The following is a description of a gene set: species: Mus musculus Mouse Gene Set: GOMF_PROTEIN_SERINE_KINASE_ACTIVITY Catalysis of the reactions: ATP + protein serine = ADP + protein serine phosphate., and this is the list of marker genes: Ern2, Mark1, Dyrk2, Rock1, Cdk11b, Mos, Pask, Prkcq, Csnk2a2, Stk38l, Atm, Nek3, Dclk3, Limk2, Sgk3, Wnk4, Ulk4, Cdkl5, Prkcb, Stk40, Tesk2, Gm4922, Alpk1, Csnk1e, Map3k4, Smg1 (SMG1 nonsense mediated mRNA decay associated PI3K related kinase), Dapk3, Alpk3, Map3k15, Pgk1, Ttn, Trpm6 (transient receptor potential cation channel, subfamily M, member 6), Clk4, Map4k5, Stk38, Chek2, Rps6ka5, Nek5, Camkk2, Pak1, Mast1, Ulk3, Prkg2, Nek6, Nek8, Tnik (NCBI Gene Id 99639), Nek1, Mast4, Atr, Ttbk1, Tssk3, Eif2ak2, Smok3b, Lmtk3, Prpf4b, Cdkl1, Clk1, Map3k9, Pkn2, Map3k10, Map2k5, Prkch (protein kinase C, eta), 4921509C19Rik, Csnk1g3, Ripk1, Cdkl4, Pdpk1, Ciita (class II transactivator), Cdk16, Eif2ak4, Lmtk2, Riok3, Bub1 (BUB1, mitotic checkpoint serine/threonine kinase), Nuak1, Stk17b, Dyrk3, Prkce, Pink1, Mapk4, Slk, Taok2, Cdk12, Mapk13, Myo3b, Camk1, Nim1k, Prkg1 (NCBI Gene Id 381235), Prkacb, Tssk4, Camkk1, Smok2a, Pak5, Tssk1, Tlk1 (NCBI Gene Id 228012), Map2k6, Pim3, Csnk1a1, Tnni3k, Pkn3, Prkd2, Map2k4, Oxsr1, Pik3ca, Wnk2, Lrrk1, Dmpk, Dapk1, Phkg1, Fam20c, Eif2ak1, Pik3r4, Aak1, Stk33, Stk-ps2, Ripk4, Gak, Fastk, Hunk, Plk3, Sgk2, Csnk2a1, Pnck, Stk32b, Mapkapk3, Nlk, Bmp2k, Hipk3, Cdk2, Hipk2, Sbk1, Ulk2, Lrrk2, Melk, Mink1, Pak3, Mak, Dclk1, Lats1, Smok3a, Gsk3a, Map3k2, Nek2, Map2k1 (mitogen-activated protein kinase kinase 1), Mapk14, Braf, Raf1, Ripk3 (receptor-interacting serine-threonine kinase 3), Mapk7, Map4k4, Stk35, Map3k6, Srpk1, Mapk6, Nek4, Csnk1g1, Cdkl3, Mknk2, Stk4, Alpk2, Tesk1, Rskr, Pskh1, Map3k12, Brsk2, Ksr1 (NCBI Gene Id 51965), Mark3, Chek1, Lats2, Cdk10, Rps6kb2, Map2k2, Srpk2, Taf1, Map4k1, Brsk1, Myo3a, Aurkb, Cdk1, Gm7168, Prkd3, Camk4, Dyrk1b, Araf, Cdk5, Map4k3, Irak1, Stk39, Mast3, Vrk1, Sik3, Snrk, Clk3, Eif2ak3, Cdk9, Cdk7, Prkcd, Cdc42bpg, Mtor, Pbk, Bckdk, Map3k5, Mapk15, Trp53rkb, Rps6ka1, Ikbkb, Map3k21, Camk2b, Pkmyt1, Stk32c, Wnk1, Rps6ka6, Plk1, Ksr2, Prkaca, Rps6ka2, Ttbk2, Tbk1, Pak2, Prkcg, Nek9, Map3k3, Prkaa2, Stk10, Nrk, Map2k7, Pim2, Dstyk, Cdkl2, Cdk8, Pak4, Cdk4, Mark2, Pik3cg, Map3k7, Stk25, Nuak2, Aurkc, Pik3cb, Riok2, Clk2, Cdk17, Hipk4, Vrk2, Dyrk4, Dyrk1a, Tnk2, Rps6ka3, Cdk18, Sbk2, Mapk12, Cilk1 (ciliogenesis associated kinase 1), Nek7, Stk36, Akt1, Pim1, Plk2, Mylk4, Aurka, Uhmk1, Stk24, Csnk1g2, Camk1g, Ttk, Sik1, Prkd1, Dapk2, Smok2b, Ankk1, Mapk9, Akt2, Mapkapk2, Mknk1, Dclk2, Rps6ka4, Rock2, Stk16, Pak6, Tssk6, Tssk5, Nek11, Ern1, Camk2a, Camk2d, Cdc42bpb, Trio (NCBI Gene Id 77730), Obscn, Riok1, Mast2, Prkaa1, Kalrn, Sik2, Map3k11, Aatk, Stk11, Csnk1d, Cdk20 (NCBI Gene Id 94183), Dcaf1, Irak4, Sgk1, Limk1, Cdk13, Srpk3, Haspin, Tlk2 (NCBI Gene Id 71049), Tssk2, Map3k20, Mapk8, Camk2g, Prkci, Rps6kl1, Hipk1, Mapk10, Cdk15, Prkca, Trpm7, Prkx, Pkn1, Bub1b, Ripk2, Gsk3b, Map3k1, Mapk3, Pikfyve, Cdk6, Bcr, Stk32a, Rps6kb1, Map4k2, Pdik1l, Stk3, Cit, Nek10, Akt3, Stk26, Plk4, Mapk11, Mark4, Camk1d, Speg (SPEG complex locus), Map3k14, Map3k8, Map3k13, Cdk14, Sbk3, Cdk19, Mapkapk5, Taok1, Cask, Ulk1, Cdc7, Taok3, Stk31 (NCBI Gene Id 77485), Prkdc, Prkcz, Mok, Map3k19, Mapk1, Cdc42bpa, Wnk3, Mastl, Rps6kc1, Map2k3